Given this list of marker genes MATN3, NAGLU, LTBP1, GLB1, PCYT1A, SLC35D1, LBR, ABCC9, TBX15, FN1, LIFR, TOMM7, SRP54, NPR2, COL2A1 (NCBI Gene Id 444981), GALNS, LTBP3, IHH, SMARCAL1, HGSNAT, SGSH, COMP, FBN1, POP1, SBDS, DNAJC21, KCNJ8, UBE3B, B3GALT6, GNS, GNPTAB, ARSB, FUCA1, ADAMTSL2, here is a description of the gene set: Ovoid vertebral bodies Human Gene Set: HP_OVOID_VERTEBRAL_BODIES studied in species Homo sapiens When viewed in lateral radiographs, vertebral bodies have a roughly rectangular configuration. This term applies if the vertebral body appears rounded or oval.